Given this list of marker genes ZNF136, TTF1, GSK3B, H4C5, SAP18, CBX3, ZNF519, MPHOSPH8, KANSL1 (NCBI Gene Id 791085), SF3B1, RRP8, YEATS2, EHMT1, SMARCA5, CD36, PAXIP1, SMARCE1, ARID1B, GPAM (NCBI Gene Id 57678), KANSL3, KAT8, MBD3, H2BC11, H3C12, KDM6A, HCFC2, SCD, PDK4, H3C2, SMARCD2, H2BC12L, TBL1XR1, AJUBA, PAGR1 (PAXIP1 associated glutamate rich protein 1), ZNF324, ZCCHC8, SMARCA2, H2BC5, ERCC3, H3C14 (H3 clustered histone 14), ABL1, ERCC2, UBE2I, ATF7IP, H2AC4, ZNF454, THRSP, ZNF331, OGT, DEK, ZNF354A, KAT14 (lysine acetyltransferase 14), MTF2, ZNF425, AGPAT2, TET3, PLIN2 (NCBI Gene Id 123), POLR1H (NCBI Gene Id 30834), PPARGC1A, H4C4, ZNF264, LPL (lipoprotein lipase, NCBI Gene Id 4023), NCOA4, H3C3, NCOA3, ZZZ3, ASH2L, DPF3, KAT2B, POLR1D, MED1, MED14, POLR2L, POLR2F, SUMO2, DPY30, H3C13, TBP, SETD1B, MED24, HDAC1, CDK7, TBL1X, SETD1A, H2AC20, MTA2, H2AC18, GTF2H4, H2BC8, KMT2A, EP300, ZNF382, MED10, SS18, H2BC6, H2AB1, CEBPA, PNPLA2, H4C1, POLR1F, DNMT1, H3C8, ZNF816, DNMT3A, ZNF33A, CREBBP, DR1, SIN3B, RBBP7 (NCBI Gene Id 5931), MED12, HDAC2, POLR2K, SPOCD1, H3-3B, MYO1C, MED4, SMARCA4, H4C6, KAT2A, POLR1G, ARID1A, H2BC17, ZNF669, SGF29, SMARCC2, BAZ2A, ZNF273, DGAT2, NCOR1, MEN1, PPARG, ZNF765, ELOVL5, SCD5, SETDB1, BOD1, EHMT2, SMARCD3, PLIN4, H3C7, RB1, CCNH, C19orf84, PHF20L1, TDG, H2BC3, POLR2H, RXRA, TAF1C, LPIN1, ZNF317, MYBBP1A, POLR2E, CCNC, ZNF28, AEBP2, SAP130, H2AX (NCBI Gene Id 3014), ZNF649, CXXC1, CBX5, KANSL2, H4C2, MED16, ZNF30, CHD4, H4C8, H4C12, RBBP4, SMARCD1, SMARCC1, SAP30L, MBIP, DDX21, JARID2, PLIN1, SAP30BP, DNMT3L, H2AC14, H2BC26, MED31, KMT2B, H2AC7, NCOR2, ACSS3, TASOR, H3C6, KMT2C, H3C11, H4C16, H2AZ2, PPARGC1B, MTA3, PEX11A, H3C10, WDR82, RBBP5, PHF19, TRIM28, TAF1A, MNAT1, GTF2H5, MED7, POLR1B, ZNF418, CHD3, NCOA6, SUZ12, MCRS1, BCL7B, H3-3A, TADA2A, HDAC3, PHF1, BOD1L1, TAF1B, DPF2, H2AC6, ZNF610, H2BC1, SIRT1, AKAP8L, ACTL6A, POLR1E, GTF2H2, TASP1, NCOA1, PHLDA1, MED27, ZNF534, PSIP1, H4C13, H2AC19, ZNF547, H4C14, CDK8, TET1 (NCBI Gene Id 80312), MED30, ZNF93, GPS2, HCFC1, WDR5, MED13, UHRF1, H4C11, DNMT3B, POLR1C, FABP4, MTREX, SAP30, SS18L1, RBM7, ZNF708, H2BC15, H2AC8, ACSL1, DPF1, BCL7C, H4C9, GATAD2A, TAF1D, ERCC6, ZNF778, TADA3, SIN3A, CDK5, H2BC10, EZH2, LIPE, MGLL, H3C15, MED6, ZNF680, MED17, GATAD2B, H2BC12, H2BC9, CIDEC, GTF2H3, ARID4B, PIWIL4, H2BC4, MBD2, EED, ZNF320, BAZ1B, ZNF257, H2BC21, ZNF224, MTA1, ADIPOQ, MED20, H2BC13, NCOA2, PHF20, BCL7A, TET2, H4C15, H2AJ, SMARCB1, H2BC7, MORC2, H3C1, UBTF, MED23, SUDS3, GTF2H1, H3C4, KMT2D, H2BC14, SUV39H1, ANGPTL4, PPHLN1, POLR1A, H4C3, ACTB, ZNF141, here is a description of the gene set: species: Homo sapiens Human Gene Set: REACTOME_EPIGENETIC_REGULATION_OF_GENE_EXPRESSION Epigenetic regulation of gene expression